The following is a description of a gene set: from publication Feuerer M, Herrero L, Cipolletta D, Naaz A, Wong J, Nayer A, Lee J, Goldfine AB, Benoist C, Shoelson S, Mathis D (PMID 19633656) species: Homo sapiens Genes up-regulated in comparison of lymph node regulatory T cells versus fat tissue regulatory T cells. Comparisons of global gene-expression profiles revealed a greater distinction between CD4+ Treg cells and CD4+ conventional (Tconv) T cells residing in abdominal (epidydimal) fat versus in more standard locations such as the spleen, thymus and LN. Human Gene Set: GSE7852_LN_VS_FAT_TREG_UP, and this is the list of marker genes: IFIT1B, CUL4B, MLX, RBCK1, WDR77, NUP205, RCCD1, PRMT9, PARS2 (NCBI Gene Id 91517), ABHD10, EIF3L, PHIP, JAGN1, C2orf68, USP40, PTPN6, NUDCD1, ERAL1, UBLCP1, TTC13, BCAP29, CAMLG, PRIMPOL, THUMPD3, TARS2, CNOT2 (NCBI Gene Id 51498), CSTF2, DNAJC3, EXOC6, CTU1 (NCBI Gene Id 90353), RFX5, C19orf12, CEP97, ZNF471, LY9, RABGAP1L (NCBI Gene Id 9910), MAPDA, PCMTD2, TOE1, MTFMT, CPT2, WDR3, RGP1, SGK3, RELCH, STRN, BMI1, CNN2, C18orf21, NAE1, EXO5, ABHD17C, NUP133, TRMT1L, PRR14L, SMC4, TMEM71, TRAF3IP2, MOGS, PATJ (PATJ crumbs cell polarity complex component), PIGN, TRMT5, STX1A, SPAG1, RNF135, CEP68, RBM22, SYNPO, SESN3, PLEKHG2, S1PR1, C2orf88, WDR73, ASXL1, PRPS2, NHLRC3, ADAMTS6, TTC27, ZNF18, RUVBL2, KPNA4, AASDH, MPP1, DCUN1D2, PUM3, FAM174B, BBX, SEH1L, MICAL1, GSAP, SFXN1 (NCBI Gene Id 94081), ST6GALNAC4, STING1, CNDP2, BAG4, CRCP, FGD6, IGIP, PPIF, LIN9, STX16, RFC5, TBC1D4, FAM118A (family with sequence similarity 118 member A), CNOT9, ARHGEF3, TMEM154, SNORD89, AIDA, TRAPPC5, NGRN, TXK, RABEPK, SLC37A4, TBC1D2B, MCMBP, CAMK2D, BZW2, PPCS, GADD45GIP1, HDAC7, PIP4K2A, SYCP3, CDCA4, ENSG00000267882, ERCC4, SLC38A1, HAUS6, SOS1, ZC3H12C, ZNF12, KDM5D, SENP8, MRPS11, TRIM34, LUC7L3, CCDC51, ABLIM1, DUS1L, RASSF2, TOP2B (DNA topoisomerase II beta), CENPO, GYPC, RASA2, DHX57, NUP160, KAT2A, ABTB3, PTGER4, GOLGA1, CSTF1, SDHA, GATA1, C6orf136, APEX1, RBM41, TRMT6, TLR7, NSUN2, HDAC10, BAZ2B, ZNF229, B4GALNT1, DAPP1, XPOT, GMPS, GPALPP1, C1GALT1, ACP5, CNOT3, SHPRH, RNF38, ZNF518A, ZNF266, CDCP1, SCAI, CD1D, MTMR4 (NCBI Gene Id 9110), OVGP1, STK38, UBR7, DRG1, CCNG2, STAT5B, ATAD3A, STARD7, TBC1D14, PTGER2, DCP1A (decapping mRNA 1A, NCBI Gene Id 55802), GMCL1, FBXO22, NT5C2, CDCA8 (cell division cycle associated 8), AHR, H2BC13, DNAJC7, INPP5F, SUGP1, TTC28 (NCBI Gene Id 23331), TOPBP1 (DNA topoisomerase II binding protein 1)